The following is a description of a gene set: Human Gene Set: HP_ABNORMAL_LYMPHATIC_VESSEL_MORPHOLOGY A structural anomaly of the vessel that contains or conveys lymph fluid. Abnormal lymphatic vessel morphology species: Homo sapiens, and this is the list of marker genes: CCBE1, MPI, PIEZO1, FLT4, FOXF1, PIK3CA, CELSR1, CD55, IFNG, RASA1, TSC1 (TSC complex subunit 1), TSC2 (NCBI Gene Id 7249), ADAMTS3, SOX18, HRAS, RNF31, FAT4